Given this list of marker genes Cobl, Cyth1, Mphosph9 (M-phase phosphoprotein 9, NCBI Gene Id 75254), Synpo, Rassf4, Lrba, Myo18a, Mapk14, Vsnl1, Mtcl1, Card6, Kcns3, Myh10, Larp4, Zfp28, Agbl2, Phlpp1, Ammecr1l, Ccn4, Sestd1, Isx, Rc3h1, Itih5, Wdr76, Arhgap19, Clock, Rab32, Rasef, Ror1, Rer1, Atf3, Ccdc88a, Selenot, Trappc3, Mrpl53, Tcf7l2, Gpcpd1, Ddx3x, Med13, Slc44a5, Eeig1, 4930402K13Rik, Cdkn2c, Rfx1, Stxbp1, Scn3b, Leprotl1, Mbtps2, Atrx, Efcab14, Vgll3, 6430571L13Rik, Gopc, Pgm2l1, Clta, Rab17, Hipk3, Tmem164, Slc1a2, Nfat5, Dsg1b, Atad1, Ccdc71l, Maml2, Rbm41, Asxl2, Bicd2, Dapp1, Dip2c, Cfl2, Zic1, Tspoap1, Tiparp, Nr3c1, Zfp800, Otor, Taf5, Mtmr3, Sidt2, Fzd3, Ifnar1, Sar1b, Dcp1a, Xbp1, Il15ra, Ttc28, Ap3s1, Sprr2f, Cdc27, Usp14, Arfgef3, Gucy1a2, Car10, Dcc, Ubqln2, Slc25a36, Zbtb34, Slc31a1, Vasn, Slain2, Nsun5, Arpc5, Nckap1, Ubap2, Ate1, Zfp119b, Dnajc27, Brms1l, Plekhh1, Ipmk, Tshz3, Tmem100 (NCBI Gene Id 67888), Ppfia3, Sec61a1, here is a description of the gene set: from publication Chen Y, Wang X (PMID 31504780) Genes predicted to be targets of miRBase v22 microRNA mmu_miR_3473d in miRDB v6.0 with MirTarget v4 prediction scores > 80 (high confidence targets). studied in species Mus musculus Mouse Gene Set: MIR_3473D